The following is a description of a gene set: studied in species Homo sapiens Genes in the cancer module 284. Human Gene Set: MODULE_284, and this is the list of marker genes: FAM3C, UGGT2, CLN5, PHLDA1, CUX1, ACADL, PPIP5K2, FXN, RSL24D1, IDO1, MAP4K2, CHD9, GABPB1, OSBPL3, INPP1, SLC23A2, ECRG4, PLXNA1, NR4A3, PCSK6, SYNC (NCBI Gene Id 81493), PGM3, IGF1R (NCBI Gene Id 51049), SMPDL3A, ASCC1, CKMT2, RPS6KA3, DKC1, PDE7A, KDR, SLC12A4, TCN2 (NCBI Gene Id 6948), PPP3CC, RHAG, DLEU2, RAP1GAP, CSPG4 (NCBI Gene Id 1464), SLC1A3, H1-3, ID2, HADHB, ABCC8 (NCBI Gene Id 6833), EPHA1, ZWINT, SLC35D1